Given this list of marker genes Pim1, Wnt5a, Tbx1, Robo1, Bmp4, Mef2c, Bmp2, Axin2, Folr1, Foxh1, Ift88, Bmpr1a, Emp2, Six1, Isl1, Ext1, Gata5, Mks1, Lrp2, Smarcd3, Robo2, Lemd2, Mesp1, Gng5, Hand2, Wnt11, Notch1, Hes1, Dkk1, Eya1, Rbpj, Tbx5, Ctnnb1, Rbm20, here is a description of the gene set: species: Mus musculus Mouse Gene Set: GOBP_HEART_FORMATION The developmental process pertaining to the initial formation of the heart from unspecified parts. This process begins with the specific processes that contribute to the appearance of the heart field and the arrival of cardiac neural crest to the heart region. The process ends when the structural rudiment is recognizable.